Given this list of marker genes TEX12, SYCE2, SYCP1, SYCE3, C14orf39, SYCE1, TEX11, INCENP, here is a description of the gene set: studied in species Homo sapiens A structural unit of the synaptonemal complex found between the lateral elements. Human Gene Set: GOCC_CENTRAL_ELEMENT